Given this list of marker genes SLC43A1, JUND, XIAP, STAG2-AS1, ZNF710, RAVER2, FAM234A, ARHGEF11, SOCS2-AS1, PABIR2, SMAD3-DT, MIR4733HG, JDP2-AS1, MALINC1, HNRNPU, AHNAK, HOXC9, MAP7D1, LHFPL2, SNX33, ATP13A3-DT, ATF3, GATA6, HOXA13, GASAL1 (NCBI Gene Id 401472), E2F3, MEX3A, SMAD6, CT66, PLEKHG3, ARHGAP5-AS1, SP1, YWHAZ, REV3L, IRF2-DT, BRD2, MIR4733, NR1D2, SLC29A2, DKFZP434A062, SERTAD2, DLEU2, ALDOA, TRAF3IP2-AS1, ITGB3, ARHGAP5, HOXD13, ATP2A2, HOXC6, KIRREL1, HELZ-AS1, SP3, LMO4, SOCS2, PTP4A2, RABGAP1L-DT, TSC22D3, AUTS2, PABIR3, RABGAP1L, ERF, HIVEP2, GPSM1, PVALB, B4GALNT3, SMAD3, JDP2, CMTM8, IRF2, MKRN1, PKM, STAG2, ATP13A3, CREBBP, DENND4B (NCBI Gene Id 9909), PITX1, TMOD1, TLK1, HOXB9, HOTTIP, here is a description of the gene set: Human Gene Set: ZNF746_TARGET_GENES from publication Yevshin I, Sharipov R, Kolmykov S, Kondrakhin Y, Kolpakov F (PMID 30445619) Genes containing one or more binding sites for (ZNF746) in their promoter regions (TSS -1000,+100 bp) as identified by GTRD version 20.06 ChIP-seq harmonization. studied in species Homo sapiens